The following is a description of a gene set: part of: G2/M Transition The centrosome is the primary microtubule organizing center (MTOC) in vertebrate cells and plays an important role in orchestrating the formation of the mitotic spindle. Centrosome maturation is an early event in this process and involves a major reorganization of centrosomal material at the G2/M transition. During maturation, centrosomes undergo a dramatic increase in size and microtubule nucleating capacity. As part of this process, a number of proteins and complexes, including some that are required for microtubule nucleation and anchoring, are recruited to the centrosome while others that are required for organization of interphase microtubules and centrosome cohesion are lost. Reactome Pathway: Centrosome maturation studied in species Homo sapiens, and this is the list of marker genes: CEP72, HAUS3, CEP43, CDK11A, CCP110, TUBG1, TUBA1A, MZT1, NME7, CEP78, CNTRL, CEP76, TUBGCP4, HAUS2, CEP164, AKAP9, PRKAR2B (protein kinase cAMP-dependent type II regulatory subunit beta), ACTR1A, OFD1, PCM1, CKAP5, HAUS4, HAUS5, MAPRE1, ODF2, CEP152, CEP135, DCTN2, HAUS1 (HAUS augmin like complex subunit 1), CPAP, CSNK1D, HSP90AA1, CDK1, ALMS1, NINL, CEP70, TUBGCP3, YWHAE, HAUS8, NEDD1, TUBGCP6, TUBB4B, CEP41, PLK4, DYNC1I2, DCTN3, PAFAH1B1, TUBB4A, TUBB, CDK5RAP2, CDK11B, CEP192, DYNC1H1, CEP290, MZT2A, DCTN1, PPP2R1A, MZT2B, CETN2, CEP63, TUBGCP5, NEK2 (NCBI Gene Id 4751), SSNA1, CEP250, PCNT, CSNK1E, PLK1, SFI1, HAUS6, DYNLL1, CEP131, TUBG2, SDCCAG8 (SHH signaling and ciliogenesis regulator SDCCAG8), YWHAG, TUBGCP2, CLASP1, PRKACA, CEP57, TUBA4A, HAUS7, NDE1